The following is a description of a gene set: Human Gene Set: GOMF_PHOSPHATIDYLINOSITOL_4_5_BISPHOSPHATE_BINDING studied in species Homo sapiens Binding to phosphatidylinositol-4,5-bisphosphate, a derivative of phosphatidylinositol in which the inositol ring is phosphorylated at the 4' and 5' positions., and this is the list of marker genes: TRPM3, SH3PXD2A (NCBI Gene Id 9644), SDCBP2, OBSCN, SYTL2, PARD3, PLCZ1, VILL, HCN1, FRMPD4, KCNQ1 (NCBI Gene Id 3784), PLCD1, SNX21, SYT9, SVIL, PLEKHA4, CAPG (NCBI Gene Id 822), HIP1R, EXOC7, PFN1 (NCBI Gene Id 5216), KCNJ3, TULP1, EXOC1, CGAS, DNM2, TULP3, TTPA, ACTN2, SESTD1, MARK1, GSDME, PICALM, MAPKAP1, JPH2, SNX20, COMMD1, CHMP3, DEFB4A, RAB35, LDLRAP1, AMER3, ANXA8, GSDMD, SYT7, VIL1, PFN2, PLCB1, SYT10, KRIT1, AMER1, RAG2, GRAMD2A, TIRAP, RPH3A, AMER2, SDCBP (NCBI Gene Id 6386), OSBPL2, TWF1, FLII, AVIL, PHLDA3, TWF2, SLC9A1, WASHC2C, GSDMA, KCNJ2, ANXA2, SNAP91, FZD7 (NCBI Gene Id 8324), GSN, GSDMB, GSDMC, SYT1, SYT5, MTSS2, KCNJ1, DNM1, ADAP2, MYO1G, MYO1B, SNX18, SCIN, HIP1, FCHO2, PLA2G4E, ALOX15